The following is a description of a gene set: Human Gene Set: GOBP_REGULATION_OF_VOLTAGE_GATED_CALCIUM_CHANNEL_ACTIVITY species: Homo sapiens Any process that modulates the frequency, rate or extent of voltage-gated calcium channel activity., and this is the list of marker genes: STAC2, STAC3, CACNB4, CALM1, GNB5, HPCA, STAC, GPR35, NIPSNAP2, CRHR1, CBARP, FMR1, CACNA1F, AHNAK, CALM3, CACNB3